The following is a description of a gene set: Human Gene Set: GOBP_ESTABLISHMENT_OF_ENDOTHELIAL_INTESTINAL_BARRIER species: Homo sapiens The establishment of a barrier between endothelial cell layers of the intestine to exert specific and selective control over the passage of water and solutes, thus allowing formation and maintenance of compartments that differ in fluid and solute composition., and this is the list of marker genes: RAPGEF2, FASN (NCBI Gene Id 2194), RAP2C, F11R, RAP2B, MYD88, CLDN1, PTPRS, RAB1A, AFDN, TJP3, TJP1, RAPGEF6, TJP2, RAB1B